Given this list of marker genes Rgs4 (regulator of G-protein signaling 4), Onecut2, Crx, Mfap1a, Zmynd8, Chml, Ikbke, Slc7a4, Ccny, 4921539E11Rik, Pa2g4 (NCBI Gene Id 18813), Gfap, Kcnc2, Kdm6a, Gabpa, Arpp21, Cfap61, Stum, Isca2, Bag5 (NCBI Gene Id 74791), Atat1, Slc35f6, Kctd14, Mfsd6, Pou3f1, Slc17a1, Kremen1, Igf2bp3, Ubr5, here is a description of the gene set: Mouse Gene Set: MIR_3099_3P species: Mus musculus from publication Chen Y, Wang X (PMID 31504780) Genes predicted to be targets of miRBase v22 microRNA mmu_miR_3099_3p in miRDB v6.0 with MirTarget v4 prediction scores > 80 (high confidence targets).